Given this list of marker genes Stau2, Efnb1, Pias2, Mapt, Otx2, Vasp (vasodilator-stimulated phosphoprotein), B3gnt2, Abl1, Ddr1, Ache, Edn3, Ttl, Adgrb3, Dcx, Nrcam, Edn1, Hprt1, Ubb, Sema3c, Disc1, Fbxw8, Arhgap33, Wnt3, Marcks, Gm2990, Lmo4, Itsn2, Spg11, Rtn4, Ptn, Slitrk2, Creb1, Epha3, Itpka, Nrxn1, App, Dicer1, Emx1, Itgb3, Efnb3, Tpbg (NCBI Gene Id 264331), Cfl1, Nedd4l, Jade2, Trim46, Apbb1, Spag9, Rims1 (NCBI Gene Id 77473), Mfn1, Tubb3, Efna5, Cpne5, Cdc42, Epha4, Tmem108, Sema3g, Trpc6, Cntn6, Sptbn4 (NCBI Gene Id 80297), Ece1, Plxna4, Nkx2-1, Vldlr, Cdh1, Stk11, Bhlhe22 (basic helix-loop-helix family, member e22), Abl2, Wasf2, Dock7, Fgfr3, Adam10, Chl1, Nek3, Bcl11b, Kif5b, Bmp7, Plppr4, Dtnbp1, Atp8a2, Prkn, Epha10, Sema3d, Eif4g2, Alcam (NCBI Gene Id 11658), Lrp2, Ext1 (exostosin glycosyltransferase 1), Slc23a2, Sh3glb1, Hecw1, Neurog3, Sema3f, Lrp8, Nckap1l, Mt3, Emb, Caprin2, Ephb2, Cdk5, Btbd3, Grip1, Pacsin1, Braf, Nkx6-1, Dbnl, Actr2, Gas1, Cckar, Smurf1, Sipa1l1, Chrna7, Pqbp1 (polyglutamine binding protein 1), Cpne6, Vps54, Thbs4, Kifbp, Islr2, Flrt1, Csf1r, Trak2, Robo3, Mir124a-2, Mir200a, Tnn, Hoxa2, Efnb2, Abi1, Lrp4, Spast, Dab1, Ankrd27, Snap91 (synaptosomal-associated protein 91), Impact, Map3k13, Col25a1, Ptprf, Plaa, Efna4, Vax2, Tbce, Sema3b, Lama1, Bcan (NCBI Gene Id 269452), Ctnnb1, Rapgef2, Dclk1, Lamc2, Nrn1l, Pou4f3, Pla2g10, Zdhhc17, Dnm3, Snx2, Rock2, Cdk5r1, Sarm1, Map6, Dixdc1, Drgx, Metrn, Dst, Arpin, Ntn1, Arx, Lrrc4c, Edn2, Pcdhac2, Mdk, Uchl1 (NCBI Gene Id 97283), Tubb2b, Stxbp1, Bsg, Atg16l1, Prmt3, Or8a1b, Obsl1, Nlgn3, Cyfip2, Ank3, Sult4a1, Septin7, Farp1, Rufy3, Adora2a, Mov10, Smo, Mir9-2, Xlr3b, Fgf13, Tnfrsf12a, Cyfip1, Arhgef25, Npr2, Nrn1, Klf7, Foxg1, Srcin1, Fgf8, Dvl2, Lamc1, Dock10, Unc5d, Nfib, Hoxa1, Rock1, Acte1, Actb, Rnf157, Prtg, Megf9, Vax1, Reg1, Mef2c, Kif1a, Pten, Lhx1, Spg21, Zdhhc15, Ptch1, Tbr1 (T-box brain transcription factor 1), Rtn4r, Fzd3, Nr4a3, Dpysl5, Gbx2, Wdr47, Aurka, Efna1, Eef2k, Zic2, Lgr4 (NCBI Gene Id 83944), Cd44, Nectin1, Dab2ip, Cd2ap, Lhx4, Slc9a6, Thy1, Dmd, Cck, Ptprj, Baiap2, Cux2, Taok3, B4galt6, Matn2, Dnm1l, Gorasp1 (NCBI Gene Id 74498), Lpar3, Unc13a, Atoh7, Elavl4, Usp33, Fxn, Cdh2, Ryk, S100b, Arhgef28, Fbxo31, Nfasc, Olfm1, Pou4f2, Lhx9, Syt17, Sema4g (NCBI Gene Id 26456), Cxcl12, Src, Ntrk2, Rere, Itga4, Itga1, Kif5a, Celsr2, Mir9-1, Ntn4, Bmpr2, Nog, Rpl24, Lamb1, Cxcr4, Zfyve27, Ttc8, Dscaml1, Bcl11a, Sema7a, Dvl3 (dishevelled segment polarity protein 3), Slitrk5, Slitrk6, Atg7, Gli2, Lama3 (NCBI Gene Id 16774), Adarb1, Nr4a2, Wee1, Ntn5, Sema4f, B4galt5, Aplp2, Limk1, Plekho1, Smad4, Cpne1, Spart, Numbl, Lhx2, St8sia2, Kel, Rtn4rl1, Vim, Ppp3ca, Ednra, Gla, Tsc22d4, Nrdc, Cacna1a, Fstl4, Cux1, Hnrnpk, Lzts1, Rpl4, Sema6a, Arhgap44, Nin, Grcc10, Spag6l, Rac1, Adnp, Tnik (NCBI Gene Id 99639), Lmx1a, Vegfa, Fam168b, Gdnf, Kif20b, Neo1, Cdh4, Epb41l3, Syt2, Isl1, Negr1, Pafah1b1, Ptprd, Fgfr2, Mfsd2a, Nes, Barhl2, Flrt3, Etv1, Trpc5 (NCBI Gene Id 22067), Apbb2, Kifc2, Id1, Sdc2, Draxin, Mypn, Chodl, Egr2, Ntn3, Dcc, Sema4b, Trak1, Lrp1, Ptprv, Mag, Wls, Kif21a, Slc25a46, Sema6c, Rab10, Cacng7, Tiam2, Actr3, Atp9a, Tunar, Nckap1, Shank3, Akap5, Lamb2, Raph1, Ssna1, Gsk3b (NCBI Gene Id 98033), Snx1, Mark2, Slc39a12, Epha8 (Eph receptor A8), Ythdf1, Ntf3, Ifrd1, Lzts3, Nkx2-9, Rbfox2, Plxna1, Dvl1, Ttc3, Nefl, Igfals, Wdr36, Tet1, Sin3a, Spag6, Cntn1, Tiam1, Afg3l2, Unc5b, Ndn, Dscam, Sema4c, Gdi1, Myh10, Trio, Shh, Tctn1, Amigo1, Ndp, Vangl2 (VANGL planar cell polarity 2), Celsr3, Plxnd1, Kif5c, Sema4d, Enah, Pak2, Golga2, Ppp1r12b, Slitrk4, Rab8a, Garem2, Wnt3a, Lama2, Foxd1, Cacna1f, Nedd4, Postn, Kirrel3, Atp7a, Abi3, Ephb6, Nbl1, Slitrk1, Isl2, Lama5, Ntng2, Plxnb2, Clasp2, Lmtk2, Tlx2, Ust, Mir9-3, Unc5a, Klk8, Ephb3, Epha7, Xk, Ngef, Fzd4, Pitpna, Clu, Pip5k1c, Sema5a, Robo1, Gja1, Dlx5, Ptpro, Map2k2, Llph, Omg, Bhlhb9, Tanc2, Slit2, Abitram (NCBI Gene Id 230234), Trpv2, Sema5b (sema domain, seven thrombospondin repeats (type 1 and type 1-like), transmembrane domain (TM) and short cytoplasmic domain, (semaphorin) 5B), Sgk1, Top2b, Etv4, Lhx3, Kidins220, Met (NCBI Gene Id 194383, met proto-oncogene), Ulk1, Bcl7a, Ctnna2, Itgb1, Tgfb2, Shtn1, Mef2a, Kank1, Cntn5 (contactin 5), Hecw2, Slc11a2, Tmem106b, Atoh1, Prickle1, Kdr, Clstn3 (calsyntenin 3), Usp9x, Pacsin2, Wnt7b, Kif13b, Fezf2, Caprin1 (NCBI Gene Id 99144), Stmn1, Rnd2, Ostn, Mbp, Shox2, Mycbp2, Cntnap1, Stxbp5, Stk25, Nsmf, Arc, Smn1, Foxb1, Map2, Mapk8, Slit3, Flot1, Taok2, Erbb2, Lgi1, Sema3a, Dact1, Zfp335, Efna2, Picalm, Reln, Psen1, Dynlt1a, Nfix, L1cam, Pou3f2, Vcl (NCBI Gene Id 268722), Slit1, Plxnc1, Sema4a, Cpne9, Mapk8ip3 (NCBI Gene Id 30957), Ret, Ctnnd2, Llgl1, Igf1r, Ccdc39, Scn11a, Adcy10, Auts2, Camk2b, Iqgap1, Muc3a, Map1b, Nyap2, Cdk5r2, Rasal1, Gli3, Runx3, Nyap1, Agrn, C9orf72, D130043K22Rik, Cntn2 (NCBI Gene Id 320300), Twf2, Lrrk2, Apc, Myo9a, Cdkl5, Mfn2, Wnt5a (wingless-type MMTV integration site family, member 5A), Rims2, Cask, Ccr5, Als2, Mir200c, Prdm8, Wasf1, Tbc1d24, Egfr, Bcl2, Fbxo45, Syt1, Mul1, Gap43, Myot, Pak3, Mink1, Gata3, Snap25, Dhx36, Ngf, Dag1, Rap2a, Hdac6, Cul7, Crppa, Anapc2, Kalrn, Plxnb1, Eif2ak4, Drd2, Bdnf, Pdpn, Nefm, Vps13a, Rreb1, Scn1b, Gfra3, Brsk1, Mir376a, Gpm6a, Ngfr, Coro1c, Ppp1r12c, Zfp365 (zinc finger protein 365), Ywhah, Mecp2, Apoe, Phactr1, Ube3a, Sema6b, Arhgap4, Neurog2, Evl, Cdh11, Rgma, Fezf1, Nptn, Ptpn11, Sema6d, Zeb2, Phox2b, Vil1, Ntrk3, Ncam1, Shank1, Nova2, Actg1, Pmp22, Rab3a, Myo5b, Ep300, Nptx1, Kdm1a, Ark2c, Gdf7, Ndel1, Nfatc4, Dbn1, Ist1, Ppfia2, Afdn, Ugt8a, Prex2 (NCBI Gene Id 98394), Slc30a1 (solute carrier family 30 (zinc transporter), member 1), Ilk, Ppp1r9a, Numb (NUMB endocytic adaptor protein), Cnp, Syngap1, Myo16, Macf1, Tuba1a, Mapk8ip2, Lamc3, Camk2a, Opa1, Chrnb2, Or10a4, Brsk2, Plxnb3, Skil, Eif2b2, Map1s, Prkca, Pak6, Ptprz1 (protein tyrosine phosphatase receptor type Z, polypeptide 1), B4gat1, Ptprh, Fn1, Grin1, Sema3e, Cntnap2, Golga4, Lamb3, Fyn, Kndc1, Artn, Nlgn1, Dip2a, Tsc2, Unc5c, Srf, Megf8, Coro1b, Igf2bp1, Nexn, Epha6, Gbx1, Syt4, Ptk2, Myo9b, Atxn2, Diaph1, Adcy1, Ppp1r12a, Mir200b, Srgap2, Map4k4 (NCBI Gene Id 98646), Rac3, Il1rapl1, Plxna3, Cit, Pdlim5, Abi2, Ulk2, Parp6, Dlg4, Enpp2, Dcdc2a, Boc, Chn1 (chimerin 1), Arhgap35, Arhgap32, Dubr, Dynlt1f, Dynlt1c, Ss18l1, Nefh, Bmpr1b, Sh3gl2, Gas7, Mir124a-1, Nell2, Ano1, Syt3, Notch3, Skor2, Zswim6, Foxp1, Wasl, Chrna3, Ablim1, Ptprm, Rab21, Pak1, Tsku, Flrt2, Cspg5, Rnf6, Aplp1, Ntrk1, Cttn, Abi3bp, Cobl, Lifr, Map2k1, Notch1, Ntf5, Diaph2, Pax6, Robo2, Dip2b, Nr2e1, Evx1, Rhpn1, Nrp2, Ptprs, Dnm2, Epha5, Ntng1, Nrp1, Mnx1, Atl1, Mgll, Wnt7a, Prkg1, Map1a, Cdkl3, Adam17, Szt2, Ephb1, Prkcz, Dynlt1b, Tnr, Efna3, Cc2d1a, Actbl2, Crabp2, Slitrk3, here is a description of the gene set: The process in which the anatomical structures of a cell projection are generated and organized. Mouse Gene Set: GOBP_CELL_PROJECTION_MORPHOGENESIS studied in species Mus musculus